The following is a description of a gene set: Mouse Gene Set: REACTOME_DOWNREGULATION_OF_ERBB2_ERBB3_SIGNALING studied in species Mus musculus Downregulation of ERBB2:ERBB3 signaling, and this is the list of marker genes: Akt1, Ubc, Nrg1, Rnf41, Erbb2, Akt2, Usp8, Rps27a, Uba52rt, Ubb, Uba52, Akt3, Erbb3